The following is a description of a gene set: Human Gene Set: GOBP_HYALOID_VASCULAR_PLEXUS_REGRESSION studied in species Homo sapiens The developmental process in which the hyaloid vascular plexus is destroyed as a part of its normal progression., and this is the list of marker genes: FLT1, TH, OPN4, SLC17A6, SLC6A3, OPN5, DRD2